Given this list of marker genes Kcnj1 (NCBI Gene Id 56379), Kcnj10, here is a description of the gene set: part of: Inwardly rectifying K+ channels species: Mus musculus electronically inferred by orthology from the curated human pathway Reactome Pathway: Potassium transport channels This event has been computationally inferred from an event that has been demonstrated in another species.<p>The inference is based on the homology mapping from PANTHER. Briefly, reactions for which all involved PhysicalEntities (in input, output and catalyst) have a mapped orthologue/paralogue (for complexes at least 75% of components must have a mapping) are inferred to the other species.